Given this list of marker genes Cav3, Nedd4l, Src, Prom2, Unc119 (unc-119 lipid binding chaperone), Cln3, Itsn1, here is a description of the gene set: Mouse Gene Set: GOBP_REGULATION_OF_CAVEOLIN_MEDIATED_ENDOCYTOSIS species: Mus musculus Any process that modulates the frequency, rate or extent of caveolin-mediated endocytosis.